Given this list of marker genes CCR6 (C-C motif chemokine receptor 6), LGALS9, CCL21, SLAMF1, CCR7, SPI1, IL12A, C1QBP, GAS6, CALR, here is a description of the gene set: studied in species Homo sapiens Human Gene Set: GOBP_POSITIVE_REGULATION_OF_DENDRITIC_CELL_CHEMOTAXIS Any process that activates or increases the frequency, rate or extent of dendritic cell chemotaxis.